The following is a description of a gene set: Human Gene Set: chr6q23 species: Homo sapiens, and this is the list of marker genes: AKAP7, RPS12, PBOV1, TAAR4P, RNA5SP218, SNORD101, FAM8A6P, RPL21P66, BCLAF1, ENSG00000286313, CCNG1P1, IL22RA2, RNA5SP219, ARFGEF3, TAAR5, AHI1-DT, KRT8P42, RN7SKP245, RPL23AP46, MAP3K5, SLC35D3, CTAGE9, MOXD1, GAPDHP73, TBPL1, HMGA1P7, RNU4-18P, LINC02865, ENSG00000287094, OR2A4, MED23, PEX7, MEMO1P2, CT69 (cancer/testis associated transcript 69), TAAR9, MYB, RPL35AP3, VNN1, ENSG00000298304, TAAR8, RPSAP42, MIR548H5, MIR3662, ENPP3, LINC02524, LINC00326 (NCBI Gene Id 285735), VNN3P, PTPN11P3, MIR548A2, TAAR7P, RPL21P67, LINC03002, SMLR1, MYB-AS1, NDUFS5P1, RBM11P1, RPL7AP37, CHCHD2P4, TCF21, ENSG00000288529, OLIG3 (oligodendrocyte transcription factor 3), SAMD3, PDE7B, HMGB1P17, AHI1, LINC01312, TAAR1, HLFP1, SNORD100, ENSG00000201807, TAAR6, NHEG1, WAKMAR2, ENPP1, EEF1A1P36, TAAR2, SIMALR, HSPE1P21, EPB41L2, EYA4, LINC01013, FTH1P26, SNORA33, LINC01010, MAP7, COX5BP2, SLC18B1, BTF3L4P3 (basic transcription factor 3 like 4 pseudogene 3), MAP3K5-AS1, STX7, MTCYBP4, SGK1, ALDH8A1, TMEM200A, MAP7-AS1, ENSG00000232876, HBS1L, TAAR3P, ARG1, LINC02539, TARID, RN7SKP299, ENSG00000308723, PERP, VNN2, SLC2A12, MTFR2, TNFAIP3, PDE7B-AS1, CCN2, IFNGR1, LINC03004, HMGB1P13, RPS29P32, RPL15P9, SELENOKP2 (NCBI Gene Id 100127908), MIR548AJ1, IL20RA, L3MBTL3, MAP3K5-AS2, RN7SL408P